Given this list of marker genes Pear1, Clec7a, Spon2, C4bp, Adgrb1, Mbl2, Tulp1, Jmjd6, Klrh1, Ighg2b, Ighg1, Lbp, Cd36, Fcgr3, Fcgr1, Sftpd, Zp3r, Myo18a, Megf10, Cfp, Scarb1, Pla2g5, Colec10, Fcnb, Cd47, Ptx3, Cd209b, Tub (NCBI Gene Id 22141), Colec11, Trem2, Colec12, Sirpa, here is a description of the gene set: species: Mus musculus Mouse Gene Set: GOBP_PHAGOCYTOSIS_RECOGNITION The initial step in phagocytosis involving adhesion to bacteria, immune complexes and other particulate matter, or an apoptotic cell and based on recognition of factors such as bacterial cell wall components, opsonins like complement and antibody or protein receptors and lipids like phosphatidyl serine, and leading to intracellular signaling in the phagocytosing cell.